The following is a description of a gene set: studied in species Homo sapiens The chemical reactions and pathways involving the transfer of one-carbon units in various oxidation states. Human Gene Set: GOBP_ONE_CARBON_METABOLIC_PROCESS, and this is the list of marker genes: GNMT, MAT2A, SHMT1, SFXN1, AHCYL1, FPGS, MTHFS, TYMS, ALDH1L1, AHCYL2, SHMT2, AHCY, MAT1A, MTHFR, DHFRP1, MTHFD1L, DHFR, MTHFD2L, DHFR2, SFXN3, MTHFD2, MAT2B, MTHFD1, ALDH1L2